Given this list of marker genes NACA, PON3, TMEM62, PSG7, CAND1 (cullin associated and neddylation dissociated 1), MTNR1A, PDIA6, EIF3M, LAX1, LRRC8D, MICALL1, COPS6, STAT4 (NCBI Gene Id 6775), RPS6, TDRKH, DHX32, RPS4X, KIF2A, CAPN2, NIPSNAP1, RPP40, PTGIR (prostaglandin I2 receptor), RPL13A, NEU2 (NCBI Gene Id 4759), MAST4, SELENOW, EHMT1, DDRGK1, DNASE2, MAGEA4, MAP3K14, GIMAP6, COX16, FOXD1, ZNF593, PEX3, MGST3, DOCK9, MALT1, GUCY1B2, MAF, RPS16 (NCBI Gene Id 6217), SCYL3, GLG1, IL26, DHRS3, FBXO21, HTATSF1, DCAF1 (NCBI Gene Id 9730), DPYD (dihydropyrimidine dehydrogenase), SSX2IP, P4HTM, OLA1, ZBTB14, COX11, TGFBR3, NRG2, ANO10, DZIP3, GPM6A, MMS19, IL10RA, CD40LG, ZNHIT6, NOLC1, VANGL1, ADH5, TTK, SUCLG2, TXN2, FAM117A, MTO1, ERBB2, NGDN, MDFIC, ACTN2, ISYNA1, SPATA7 (NCBI Gene Id 55812), RPL36, CHD1L, HSPB1 (heat shock protein family B (small) member 1), CSNK2A2, HABP4, PABPC3, PSG1, RYR3, CAMTA1, PCBP3, FRYL, ATP6V0E2, CASP8AP2, SLC18A3, RPA1, PAM, MRTFB, FBL, DYNLT1, CTSH, RPL4, ZBED5, SESN1, SH2D3A, PFDN4, RAD17, TOP2A, PRKACB, DUSP14, ITGB1, APPL1, AMMECR1, SLC25A6, KCNC4, QSER1, FTO, PREP, NMD3 (NCBI Gene Id 51068), PARD6A, POLR1G, METRN, GNPDA1, MAP3K4, EPB42, FH, RBMXL2, ATM, BZW2, TTC27, HSPA8 (heat shock protein family A (Hsp70) member 8), HGH1, ABCC5, KDM7A, RGS9, CABYR, ESM1, MFHAS1, F8, CYP2E1, TRAPPC2, METTL1, DTWD1, RO60, CALR, AZGP1, MFSD13A, RESF1, PWP1, ENDOD1, CD320, SEMA4C, LY6E, DNAJC10, ADK, MRPL3, PFAS, TMEM134, ITPR3, COPZ1, RAB3GAP2, NQO1, IARS2, RPL22, SMIM7, LMAN2L, WNT1, RUVBL1, IFT140, KCNH4, GALK1, ATP5IF1, WDR3, KCNA3, ADGRA3, DIMT1, CD99, MCTS1, TARP, H4C6, PIK3C2B, SPOCK2, HNRNPA1, FBXO40, UBXN8, ZNF76, GARRE1, THAP12, CROCCP2, STK38, HLA-DPB1, GFI1, BAD, AKR1A1, MTCH2, CLEC2D, CYP4A22 (cytochrome P450 family 4 subfamily A member 22), ETS2 (NCBI Gene Id 2114), TRPC7, PHYH, SLC6A2, here is a description of the gene set: from publication Jeffrey KL, Brummer T, Rolph MS, Liu SM, Callejas NA, Grumont RJ, Gillieron C, Mackay F, Grey S, Camps M, Rommel C, Gerondakis SD, Mackay CR (PMID 16474395) Human Gene Set: GSE3982_EOSINOPHIL_VS_EFF_MEMORY_CD4_TCELL_DN Genes down-regulated in comparison of eosinophils versus effector memory CD4 T cells. In the present study we used Affymetrix oligonucleotide microarrays to produce gene transcription profiles for the major leukocyte types in humans. This comprehensive dataset enabled us to not only establish which genes were expressed in each leukocyte type, but also which genes were expressed in each subset after activation. The used of a comprehensive dataset of gene profiles from all the major human leukocyte subsets enabled a novel and powerful means for identification of genes associated with single leukocyte subsets, or different immune paradigms. species: Homo sapiens